The following is a description of a gene set: Neuroendocrine (NE) phenotype, seen in >30% of prostate adenocarcinomas (PCa), and NE prostate tumors are implicated in aggressive prostate cancer. Formation of NE prostate tumors in the TRAMP mouse model was suppressed in mice lacking the ubiquitin ligase Siah2, which regulates HIF-1alpha availability. Cooperation between HIF-1alpha and FoxA2, a transcription factor expressed in NE tissue, promotes recruitment of p300 to transactivate select HIF-regulated genes, Hes6, Sox9, and Jmjd1a. These HIF-regulated genes are highly expressed in metastatic PCa and required for hypoxia-mediated NE phenotype, metastasis in PCa, and the formation of NE tumors. Tissue-specific expression of FoxA2 combined with Siah2-dependent HIF-1alpha availability enables a transcriptional program required for NE prostate tumor development and NE phenotype in PCa. studied in species Mus musculus Mouse Gene Set: QI_HYPOXIA from publication Qi J, Nakayama K, Cardiff RD, Borowsky AD, Kaul K, Williams R, Krajewski S, Mercola D, Carpenter PM, Bowtell D, Ronai ZA (PMID 20609350) Genes up-regulated by hypoxia in TRAMP-C cells (prostatic cancer)., and this is the list of marker genes: Igfbp3, Pfkp, Il13ra1, Fzd1, Hk1, Pgam1, Gch1, Ostf1, Abcb6, Siah2, Hmgcl, Vegfa, Lss, Egln3 (egl-9 family hypoxia-inducible factor 3), Sertad1, Homer1, Jmjd6, Spg21, Irx2, Cdc42ep2, Kdelr3, Kcnk2, Espn, Grhpr, Kdm4b, Ctns, Mt2, Mxi1, Ddit4, Map3k1, Bcl2l11, Arrdc3, Cd109, Ndrg1, Pkp2, Plod2, Sqle, Mpp2, Nrn1, Me2, Pdxp, Pgf, Gls2, Lox, Bhlhe40, Kcnb1, Ak4, Galr2, Bnip3, Plod1, Triobp (NCBI Gene Id 545118), Acat2, Hk2, Ndrg2, Ampd3, Scd2, P4ha1 (NCBI Gene Id 18451), Elmo1, Slc2a1, Aldoc, Trerf1, Pgm1, Ppp1r3b, Hes6, Efna1, Adm, Hdac5, Pfkl, Hpse, Fam117b, Acap1, Acss2, Reep1, Dixdc1, Gpr146, Adipor2, Rasl12, Mboat2, Foxo3, Kif21b, Vldlr, Sh3yl1, Cdhr1, Rnf126, Ccng2, Krt19, Rnf19a, Sap30, Acer2, Cdkn1a, Car9, Gtf2e2, Gpi1, Cyp51, Aldoa, Egln1, Tnfsf9, Itpk1, Ppp1r3c, Atg9b (NCBI Gene Id 213948), Ffar4, Gbe1, Pafah1b3, Cyp2s1, Insig1 (insulin induced gene 1), Col12a1, Naa80, Whamm, Casp6, Gpr35, Hmox1, Sox9, Capn5, Ier3, P4ha2, Lpin1, Dusp1, Cryab, Slc19a2, Stc1, Higd1a, Vhl, Pcyt1b, Rora, Zbtb8b, Dyrk1b, Ciart (circadian associated repressor of transcription), Itga11, Pdk1, Slc41a2, Plekha2, Nsdhl, Mvd